The following is a description of a gene set: Human Gene Set: HP_PERIPHERAL_EDEMA species: Homo sapiens An abnormal accumulation of interstitial fluid in the soft tissues of the limbs. Peripheral edema, and this is the list of marker genes: ZNHIT3, PRKAG2, TLL1, FLNC, FSHR, TNNT2, KIF20A (NCBI Gene Id 94421), EPHB4, MYPN, TNNI3, SLC34A2